The following is a description of a gene set: species: Homo sapiens Human Gene Set: REACTOME_NADE_MODULATES_DEATH_SIGNALLING NADE modulates death signalling, and this is the list of marker genes: CASP2, BEX3, NGFR, YWHAE, CASP3, NGF